Given this list of marker genes GLCCI1, C8orf34, HIVEP2, SOX10, ALCAM, STEAP3, OR11A1, USP15, WNK1, KIAA1671, ANXA7, TTI2, SANBR, NIPSNAP2, GSPT1, CLTC, DNAJA2, RPL26L1, PLPPR5, PHIP, GMEB1 (glucocorticoid modulatory element binding protein 1), RASA1, GATAD1, TRIP13, KLC4, ZFP36L1, CCDC6, CCNT2, SPACA7, AFF4, CA8, LATS2, AGTR1, ATP8B4, FZD6, TMEM132B, ZNF532, PRPF4, C6orf120 (chromosome 6 open reading frame 120), CKLF, PLEKHB2, FAM222B, YWHAQ, RORA, OCLN, HTR5A (NCBI Gene Id 3361), PDCD6IP, MAPKAPK5, TNFSF15, ZDHHC15, RGS4, GRIN2D, ACVR2B, DYNC1I1, RMDN2, SIGLEC8, TFB1M, ABHD17C, IP6K2, ZNF548, LIPG, PAXBP1, MID1, HMCN1, PYGO1, CNIH1, SEMA6A, VBP1, ASPH (NCBI Gene Id 56921), YOD1, APLF, DISC1, LRRTM2, here is a description of the gene set: from publication Chen Y, Wang X (PMID 31504780) Human Gene Set: MIR4491 Genes predicted to be targets of miRBase v22 microRNA hsa-miR-4491 in miRDB v6.0 with MirTarget v4 prediction scores > 80 (high confidence targets). species: Homo sapiens